Given this list of marker genes LYPD6B, S100A4 (NCBI Gene Id 6275), SQLE, GCSH, PDZD2, BRD2, RPL21, TTC3, SERPINE1, CREG1, S1PR3, MIR4435-2HG, FRMD4B, ZCRB1, EFNA1, MAB21L1, CTNNAL1, SETBP1, KLF10, SLC16A1, FAT1, CXADR, GGA2, HSP90AB1, CSNK1E, ENY2, PMEPA1 (prostate transmembrane protein, androgen induced 1), CRIM1-DT, BCL2L13, EPB41L4A, DGKG, EFNA5, PPP1R15A, DIPK2A, EGR2, STX2, CADM3, MAST4, RAB28, RPL6, PLCXD3, INHBB, NCAM1, ALDH1A3, TGM2, HSPG2, TPMT, GSTM5, CIMAP1B, RPS19, MXD1, VTI1B, RBP1, MAFF, NCEH1, SLC20A1, MIDEAS, DSC2, TXNDC12, COMMD6, DNAJC6, ERICH5, PLP2, SPOCK1, MKNK2, JAM3, PBX1, SGCB, SLC36A4, CDK6, MYO1B, COX7A2L, HK2, EPHA2, RERE, THY1, NLGN1, ZDHHC2, CRIP2, CKS2 (NCBI Gene Id 1164), COL4A6, SIX3, MAFK, here is a description of the gene set: studied in species Homo sapiens Human Gene Set: GAUTAM_EYE_IRIS_CILIARY_BODY_CRYAA_HIGH_CILIARY_BODY_CELLS from publication Gautam P, Hamashima K, Chen Y, Zeng Y, Makovoz B, Parikh BH, Lee HY, Lau KA, Su X, Wong RCB, Chan WK, Li H, Blenkinsop TA, Loh YH (PMID 34584087) Occular cell types curated from Gautam and Hamashima et al. Multi-species single-cell transcriptomic analysis of ocular compartment regulons